The following is a description of a gene set: from publication Motenko H, Neuhauser SB, O'Keefe M, Richardson JE (PMID 26092688) studied in species Mus musculus Mouse Gene Set: MP_INCREASED_ACUTE_LYMPHOBLASTIC_LEUKEMIA_INCIDENCE Mouse genes annotated to increased acute lymphoblastic leukemia incidence (MP:0010336) retrieved from the Mouse Genome Informatics database via MouseMine, and this is the list of marker genes: Eef1a1, Mcm4, Cdkn2a, Ptpn11, Prdm14, Nras, Lmo2, Notch3, Pten (NCBI Gene Id 70161)